The following is a description of a gene set: Human Gene Set: WP_METABOLIC_REPROGRAMMING_IN_PANCREATIC_CANCER species: Homo sapiens Metabolic reprogramming in pancreatic cancer, and this is the list of marker genes: PGM3, RPE, CS, HMGCS2, SLC43A1, ME1, HMGCR, GPI, DLD, GNPNAT1, HK1, GPT, SLC16A4, GOT1, ACLY, SLC1A5, GLUD1, CARM1, PDHB, PDHA1, GFPT1, BCAT2, UAP1, LDLR, GOT2, RPIA, SLC16A1, PKM, MDH1, TP53, SOAT1, BCKDHA, KRAS, LDHA, HK2, GLS2, PFKL, SLC2A1, PDHX, SLC7A5, DLAT, FASN